Given this list of marker genes Tuba3b, Psmd2, Nsl1, Ube2i, Psmc5, Cc2d1b, Aurkb, Psma2, Psmc4, Cdc23, Pds5a, Ranbp2, Dync1h1, Chmp4b (charged multivesicular body protein 4B), Nup93, Spdl1, Ubb, Rbm39, Tuba8 (tubulin, alpha 8), Ercc6l, Cenpl, Chmp6, Sirt2, Ndc1, Dsn1, Mad1l1, Nup188, Ppp2r5d, Pds5b, Anapc2, Tubb6, Psma7, Dync1i1, Ppp2r5a, Psmd6, Ckap5, Ube2s, Cenps, Spc24 (NCBI Gene Id 67629), Kif2b, Ahctf1, Mis12, Tuba1c, Dynll2, Cenpk, Tubb4a, Rps27a, Ppp2r1b, Sgo1, Stag1, Chmp2b, Cdc26, Ska1, Cenpm, Psmd3, Banf1, Anapc15, Cenpn, Mad2l1, Ppp2r5e, Psma1, Pmf1, Ccnb1, Psmc6, Cenpf, Chmp7, Uba52, Mapre1, Ppp2ca, Ccnb2, Cdca8, Psmb3, Nup35, Spast (NCBI Gene Id 54171), Smc1a, Psmd12, Rcc2, Bub3, Dync1li1, Tubb4b, Psmb7, Wapl, Psmd7, Sumo1, Nup85, Clasp1, Ankle2, Vrk1, Ran, Pttg1, Psmd13, Tubb1, Spc25, Nde1, Anapc7, Anapc5, Ube2c, Ndc80, Anapc4, Anapc16, Smc3, Ppp2r5c, Psma6, Lmnb1, Nup155, Anapc11 (NCBI Gene Id 97770), Tubb2b, Psmb6, Anapc10, Bub1b, Ska2, Ppp2r2a, Rcc1, Psmb2, Psmc2, Nup205, Pafah1b1 (platelet-activating factor acetylhydrolase, isoform 1b, subunit 1), Kntc1, Sgo2a, Ppp2r1a, Cdc27, Espl1, Hdac8 (NCBI Gene Id 70315), Lmna, Chmp2a, Zw10, Tuba1a, Chmp4c, Dync1li2, Cenpo, Psma4, Cenpe, Ppp2r5b, Vrk2, Nup160, Tubb3, Psmb4, Chmp3, Cenph, Xpo1, Psmd14, Cenpt, Ndel1, Ube2d1, Psmc1, Kif2a, Kif18a, Dynll1, Nup43, Kif2c, Psmc3, Clasp2, Tubal3, Psmd8, Cdk1, Rangap1, Psmd11, Tubb2a, Cdc16, Kpnb1, Zwilch, Incenp, Ist1, Emd, Cenpp, Cenpi, Uba52rt, Dync1i2, Tuba3a (tubulin, alpha 3A), Bub1, Ubc, Rps27, Taok1, Tuba1b, Cenpq (centromere protein Q), Rps27rt, Adrm1, Anapc1, Ube2e1, Cenpa, Rad21, Psmb5, Nup98, Itgb3bp, Psmd1, Clip1, Psmb1, Cdc20, Ppp2cb, Pom121, Nup107, Seh1l, Cdca5, Nup37, Stag2, Cenpc1, Nudc, B9d2, Nup133, Vps4a (NCBI Gene Id 78220), Sec13, Psma3, Plk1, Cenpu, Psma5, Fbxo5, Nuf2, Ppp1cc, Zwint (ZW10 interactor), Tuba4a, Lbr, here is a description of the gene set: species: Mus musculus Mitotic Metaphase and Anaphase Mouse Gene Set: REACTOME_MITOTIC_METAPHASE_AND_ANAPHASE